Given this list of marker genes Cldn2, Krt8, Cldn1, Matn2, Ogn, Calml4, Msx1, Aga (NCBI Gene Id 234256), Npr3, Sgk1, Ecrg4, Ttr, Aqp1, Mcee, Ocln, Krt18, Dnai3, Myo7a, Sostdc1, here is a description of the gene set: studied in species Mus musculus Genes selectively expressed by choroid plexus epithelial cells in embryonic day 14.5 mouse telencephalon. Mouse Gene Set: HEVNER_TELENCEPHALON_CHOROID_PLEXUS_EPITHELIAL_CELLS from publication Bedogni F, Hevner RF (PMID 34321999)